Given this list of marker genes EVPL, ANXA1, KRT2, COL3A1, TGM3, TGM2, CSTA, F13A1, FN1, FLG, SPRR1A, SPRR1B, KRT1, DSP, IVL, THBS1, SPRR2E, LORICRIN, PI3, KRT10, TGM1, here is a description of the gene set: studied in species Homo sapiens Human Gene Set: GOBP_PEPTIDE_CROSS_LINKING The formation of a covalent cross-link between or within protein chains.